Given this list of marker genes Ncor2, Sap30, Maml1, Hes5, Psen2, Notch2, Psenen, Wdr12, Spen, Gsk3b, Notch3, Furin, Pofut1, Mapk3, Tle1, Mef2c (NCBI Gene Id 71350), Yy1, Lck, Tcf3, Psen1, Hey2, Notch1, Maml2, Stat3, Notch4, Trp53, Dtx1, Maml3, Smad4 (NCBI Gene Id 28063), Fbxw7, Sin3a, Dll1, Ccn3, Jun, Cir1, Aph1b, Ncor1, Pik3r1, Ncstn, Egf, Numbl, Cntfr, Adam17, Smad3, Mfng, Smad1, Hivep3, Ep300 (NCBI Gene Id 328572), Cdk2, Hdac2, Itch, App, Hdac1, Hey1, Pik3r2, Nfkbia, Egfr, Jag1, Numb, Lfng, Lef1, Dll4, Adam10, Jag2, Cntf, Mapk1, Rbpj, Magea1, Cntn1, Snw1, Fhl1, Hes6, Jak2, Cul1, Skp1, Rela, Zfpm1, Akt1, Ring1, Skp2, Hes1, Ascl1, here is a description of the gene set: Delta-Notch signaling pathway Mouse Gene Set: WP_DELTANOTCH_SIGNALING_PATHWAY species: Mus musculus